Given this list of marker genes Edn3, Prkn, Pou4f2, Sema7a, Mapt, Myocd, Auts2, Nfix (NCBI Gene Id 18032), Megf8, Agt, Disc1 (disrupted in schizophrenia 1), Clstn3, Cttn, Gsk3b, Sema3a, Slc39a12, Cdk5, Pak1, Edn2, Jade2, Slc25a4, Fxn, Prkg1, Cdkl5, Efna5, Shtn1, Ttl, Gdf9, Sema5b, Ntrk3 (NCBI Gene Id 414121), Lrp1, Npr2, Itga4, Tnfrsf12a, Eif2b2, C9orf72, Flrt3, Cpne6, Rgma (repulsive guidance molecule family member A), Nrn1, Fubp1, Abl1, Ep300, Aurka, Sox9, Ndel1, Ostn, Smad7, G6pd2, Map2, Pten, Dip2b, Rarg, Dbn1, Ntn1, Pou4f3, Ddx39b, Adcy10, Islr2, Csf1r, Cdh1, Vegfa, Trim46, Nedd4l, Ulk2, Dbnl, Syt2, Hamp2, Tiam1, Sema4f, Pin1, Zfyve27, Zeb2, Nlgn3, Rims2, Adra1a, Cobl, Mt3, Itgb1, Meis1, Srf, Pafah1b1, Ulk1, Rgs4, Ddr1, Arhgap32, Syt1, Eif2ak4, St8sia2, Dyrk1a, Cyfip2, Camk2d, Smo, Slc23a2, Foxp1, Cacng7, Rab21, Igf1, Nr3c1, App, Ppara, Bcan, Akap6, Lamb2, Cst5, Itsn2, Pdlim5, Vcl, Spart, Epha7, Pin1rt1, Plxna4, Adra1b, Kdm1a, Cd2ap (CD2-associated protein), Draxin, Barhl2, Mul1, Sema4d, Smurf1, Rnd2, Kmt2d, Gsk3a, Prkcz, Fgf13, Dscam, Rgs2, Mecp2, Map2k4, Lpar3, Slit3, Agtr2, Tnr, Crabp2, Ednra, Sirt1, Macf1, Septin7, Ctdp1, Yy1, Gdi1, D130043K22Rik, Prmt2, Slit2, Arih2, Syt4, Reg1, Myo5b, Cdkl3, Wnt5a, Alcam, Bcl11a, Dcx, Ngf, Gata4, Spag6, Mtor, Sirt6, Rnf6, Rnf157, Cxcr4, Tnn, Cyfip1, Nrp1, Flrt1, Atg16l1, Bmpr2, Nrp2, Sin3a, Cpne1, Plaa, Rpl4, Fdps (NCBI Gene Id 99573), Slit1, Olfm1, Parp2, Spg21, Ryk, Hnrnpk, Stk11, Edn1, Adrb1, Spag6l, Emx1, Trpc5 (transient receptor potential cation channel, subfamily C, member 5), Raph1, Col14a1, Arhgap4, Hamp, Twf2, Slc9a6, Rasal1, Llph, Unc13a, Limk1, Rufy3, Ptprs, Dclk1, Ilk, Robo1, Fstl4, Spg11 (NCBI Gene Id 98786), Tsc22d4, Shbg, Rbm10, Plxna3 (NCBI Gene Id 18846), Mex3c, Dcaf13, Bdnf, Syt3, Cav3, Hdac6, Pak6, Sorbs2, Wdr36, Ifrd1, Zfp418 (zinc finger protein 418), Nkx6-1, Mgll, Dvl1, Prickle1, Clasp2 (NCBI Gene Id 97514), Ctnnb1, Eif4g2, Mir124a-1, Dnm2, Sema6c, Plxna1, Mag, Adnp, Postn, Akap13, Ttc3, Afdn, Ndn, Tgfbr2, Wnt3, Rtn4r, Map1b, Ext1, Sema6d, S100b (NCBI Gene Id 20203), Usp9x, Wnt3a, Pi16, Slitrk1, Impact, Nin, Sema5a, Ccn4, Ccr5, Lhx2, Garem2, Cpne9 (copine family member IX), Trpv2, Tomm70a, Sh3glb1, Actr3, Picalm, Fn1, G6pdx, Anapc2, Map3k13, Rims1, Apoe, Syt17, Sema3g, Ssna1, Cdh4, Ang2 (NCBI Gene Id 11731), Trip10, Ist1, Tmem108, Omg, Sema3f, Golga4, L1cam, Sh3gl2, Iqgap1, Spag9, Mir124a-2, Rtn4, Cxcl12, Cpne5, Nrn1l, Pum2, Wasf1, here is a description of the gene set: Mouse Gene Set: GOBP_DEVELOPMENTAL_CELL_GROWTH The growth of a cell, where growth contributes to the progression of the cell over time from one condition to another. species: Mus musculus